The following is a description of a gene set: Human Gene Set: REACTOME_TOLL_LIKE_RECEPTOR_TLR1_TLR2_CASCADE Toll Like Receptor TLR1:TLR2 Cascade species: Homo sapiens, and this is the list of marker genes: LY96, UBA52, TRAF2, TLR2, ATF1, USP14, RPS6KA5, CD14, IKBKB, IRAK3, SFTPA1, MAPKAPK2, CHUK, APP, S100A1, S100A9, RPS6KA1, ELK1, CREB1, VRK3, ALPK1, DUSP3, NFKBIB, N4BP1, NOD1, UBB, ECSIT, RPS27A, FOS, IRAK2, RELA, MAP2K6, MEF2C, TAB3 (NCBI Gene Id 257397), SIGIRR, NOD2, TAB1, MAP3K8, S100A8, TLR1, SAA1, PELI1, TAB2, NLRX1, AGER, MAPK3, PELI2, TNIP2, MAPK14, MAP2K7, MAP2K3, RPS6KA3, MAPK7, TLR4, TIFA (TRAF interacting protein with forkhead associated domain), SOCS1, PPP2R5D, DUSP6, UBE2N, NKIRAS2, ATF2, NFKB1, MAP3K7, NKIRAS1, FGB, RIPK2, TIRAP, HMGB1, CD36, NFKB2 (nuclear factor kappa B subunit 2), CASP8, MAPK1 (NCBI Gene Id 5594), TLR6, BTK, MAP2K1, PPP2R1A, S100B, SFTPA2 (surfactant protein A2), SKP1, PPP2CB, LRRC14, CUL1, IRAK4, UBE2V1, TRAF6, DUSP4, DUSP7, MAPK11, PPP2CA, MAPKAPK3, NFKBIA, JUN, USP18, IRAK1 (NCBI Gene Id 3654), MAPK8, MEF2A, TP53, FGA, MAP2K4, IKBIP, PPP2R1B, PELI3, MAP3K1, FBXW11, UBC, MAPK9, NLRC5, BTRC, MYD88, IKBKG, SFTPD, FGG, RPS6KA2, S100A12, MAPK10